The following is a description of a gene set: Any process that stops, prevents or reduces the frequency, rate or extent of dendritic spine maintenance. species: Homo sapiens Human Gene Set: GOBP_NEGATIVE_REGULATION_OF_DENDRITIC_SPINE_MAINTENANCE, and this is the list of marker genes: CFL1 (NCBI Gene Id 1072), MIR30B, APOE, PRNP, GRIN2B, FYN